Given this list of marker genes Cited1, Dspp, Ctnnb1, Lif, Gdnf, Six2, Stat1, Wt1, Pax2, Fzd7, Sall1, Wnt9b, Wnt4, Tcf15, Pax8, Gata3, Pelo, Smo, Dsg2, Grem1, here is a description of the gene set: species: Mus musculus Mouse Gene Set: GOBP_MESENCHYMAL_TO_EPITHELIAL_TRANSITION A transition where a mesenchymal cell establishes apical/basolateral polarity, forms intercellular adhesive junctions, synthesizes basement membrane components and becomes an epithelial cell.